Given this list of marker genes Apoe, Rpl31-ps12, Dcn, H3f3b, Rpl6, Spp1, Eef1d, Fzd9 (NCBI Gene Id 14371), Rhoc, Crip2, Slc25a3, Rpl14, Pdlim2, Rpl4, Fth1, Srgn, Ifitm2, Hspb1, Rps3, Swi5, Rpl17, Rps6, Cygb, Hsp90ab1, Rps5 (NCBI Gene Id 20103), Laptm4a, Clic1, Tmsb10, Hoxa7, Rsrp1, Arpc1b, Eif3f, Naca, Pfn1, Pebp1, Tmem176a, Cdc42ep3, Fxyd5, Fxyd6, Jund, H2-K1, Ptma, Sfn, Comp, Wdr89 (NCBI Gene Id 72338), Dnajb1, Rack1, Cdkn1a, Map1lc3a, Calml3, Rpl3, Ubb, Cdkn1c, Rabac1, Tpt1, Rpl11, Cd9, Cst3, Cfl1 (cofilin 1, non-muscle), Rbp4, Use1, Ftl1, Rpl7, H2-D1, Npm1, Pltp, Pfdn5, Rpl8 (ribosomal protein L8), Gm9320, Rrad, Ly6c1, Bsg, Lgals3, Gpnmb, Selenow, Kdm6b, Scgb1a1, Pcolce2, Cbr2, Fbln7, Cd63, Ldhb, Rpl13a (ribosomal protein L13A), Cxcl1, Rps20, Capg, Rps10, Nbl1, Cox7a2l, Cpne8, Rps3a1, Ubb-ps, Ier2, Selenom, Ecrg4, Prr13, Gpx3 (glutathione peroxidase 3), C4b, Cadm1, Apod, Reg3g, Rplp0, Ier3 (NCBI Gene Id 15937), Prg4, Tmem176b, Ly6a, Chad, Ninj1, Rpl13, Rps4x, Rpsa, Igfbp7, Rps15a-ps6, Rps7, Rps9 (ribosomal protein S9), Gm6402, here is a description of the gene set: studied in species Mus musculus Mouse Gene Set: TABULA_MURIS_SENIS_TRACHEA_FIBROBLAST_AGEING from publication Tabula Muris Consortium (PMID 32669714)